Given this list of marker genes THBS2, SPP1, C1QTNF5, ANXA5, LOXL2, SFTPD, FNDC1, HMCN1, BMP1 (NCBI Gene Id 649), AGRN, SERPINB1, PLOD1, HTRA1 (NCBI Gene Id 5654), ST14, F2, GPC4, PXDN, TIMP1, HCFC1, C1QB, HPX, COMP, MUC16, SERPINE2, C1QA, IGFALS, EFEMP2, COL22A1, LTBP2, MXRA5, here is a description of the gene set: Human Gene Set: NABA_MATRISOME_METASTATIC_COLORECTAL_LIVER_METASTASIS from publication Naba A, Clauser KR, Whittaker CA, Carr SA, Tanabe KK, Hynes RO (PMID 25037231) studied in species Homo sapiens Matrisome proteins found differentially expressed in secondary colorectal liver metastatases in comparison to normal colon and normal liver. In order to identify candidate biomarkers, we sought to define ECM signatures of metastatic colorectal cancers and their metastases to the liver. We obtained patient-matched metastatic colorectal cancer samples (primary tumor and paired metastases to liver) and normal colonic tissue from three patients from Massachusetts General Hospital s tissue bank. We also obtained normal liver tissue from healthy donors. We have used enrichment of ECM from human patient samples and proteomics to define the ECM composition of primary colon carcinomas and their metastases to liver in comparison with normal colon and liver samples. We defined, for each tissue or tumor type, its matrisome as the ensemble of proteins detected in at least two of the three patients studied. Based on these changes, we derived ECM protein signatures of primary colon carcinoma and primary colon tumor metastasis to liver. Comparisons of these signatures with available clinical gene expression array data show that subsets of these signatures correlate well with tumor progression and metastasis. Importantly, we identified subsets of tumor-specific proteins either characteristic of the colon tumor matrisome or characteristic of the metastasis matrisome. This gene set lists the matrisome proteins detected either exclusively or in significantly higher abundance in colorectal liver metastases compared to normal colon and liver.